Given this list of marker genes Tnfrsf4, Tnfsf15, Tnfrsf11b, Tnfrsf9, Tnfsf13, Tnfrsf25, Tnfrsf18, Cd70, Edar, Tnfrsf14, Tnfsf13b, Eda2r, Tnfsf4, Tnfsf11, Cd27, Edaradd, Tnfrsf8, Tnfrsf1a, Lta, Eda, Tnfrsf1b, Tnfsf9, Tnfsf8, Tnfsf18, Tnfrsf17, Tnfrsf13b, here is a description of the gene set: studied in species Mus musculus TNFs bind their physiological receptors Mouse Gene Set: REACTOME_TNFS_BIND_THEIR_PHYSIOLOGICAL_RECEPTORS